The following is a description of a gene set: species: Homo sapiens Pathway Definition from KEGG: TGFB -> (TGFBR2+TGFBR1) -> (SMAD2,SMAD3) == SMAD4 Human Gene Set: KEGG_MEDICUS_REFERENCE_TGF_BETA_SIGNALING_PATHWAY TGF-beta signaling pathway. Pathway ID: N00063. Pathway type: Reference. Pathway class: nt06507 TGFB signaling., and this is the list of marker genes: SMAD4 (NCBI Gene Id 4089), TGFB3 (NCBI Gene Id 7043), TGFB1, TGFBR1, SMAD3, SMAD2, TGFBR2, TGFB2